The following is a description of a gene set: studied in species Mus musculus Mouse Gene Set: GOBP_PROTEIN_LOCALIZATION_TO_POSTSYNAPSE Any process in which a protein is transported to, and/or maintained at the postsynapse, the part of a synapse that is part of the post-synaptic cell., and this is the list of marker genes: Agrn, Gphn, Ghsr, Grin2a, Zdhhc15, Cacng3, Stx3, Ogt, Grip2, Cacng2, Map2k1, Vwc2, Rab11a, Neto2, Neto1, Gpsm2, Stx4a, Rapgef4, Camk2a, Erbb4, Scrib, Musk, Arhgap44, C1ql3, Magi2, Dlg4, Nrxn3, Iqsec2, Dlg2, Rab8a, C1ql2, Cacna2d2 (calcium channel, voltage-dependent, alpha 2/delta subunit 2), Gripap1, Nptx1, Gpc4, Prkcz, Mapk10, Dlg1, Dag1, Clstn1, Vps35, Adam10, Tnik, Tmem108 (NCBI Gene Id 81907), Lhfpl4, Grin1, Nbea, Gabarap, Sacm1l, Cnih3, Gpc6, Cacng7, Olfm2, Hras, Dok7, Nptxr, Lrrc7, Kif2c, Cplx1, Nptx2, Kalrn, Epb41l1, Rap1a, Stx1b, Adam22, Snap47, Traf6, Vps26b, Vamp2, Mylk, Grin2c, Erbb2, Rapsn, Nsg1, Zdhhc2, Git1 (GIT ArfGAP 1), Lgi1, Gsk3b, Grip1, Snap23